The following is a description of a gene set: studied in species Mus musculus The directed movement of catecholamines, a group of physiologically important biogenic amines that possess a catechol (3,4-dihydroxyphenyl) nucleus and are derivatives of 3,4-dihydroxyphenylethylamine. Mouse Gene Set: GOBP_CATECHOLAMINE_TRANSPORT, and this is the list of marker genes: Hrh3, Slc18a1, Tor1a, Sdhd, Gck, Grm2 (glutamate receptor, metabotropic 2), Drd2, Kcna2, Syt1, Kcnb1, Dtnbp1, Rtn4, Adora2b, Chrnb2, Slc22a1, Tgm2, Ptgs1, Drd3, Cnr1, Ghsr, Pink1, Adora3, Oxtr, Crhr1, Oxt (NCBI Gene Id 18429), Slc29a3, Slc29a4, P2ry1, Mapk15, Npy2r (neuropeptide Y receptor Y2), Grk2, Htr1b, Entpd1, Cadps, Chrna4, Mecp2, Syt4 (NCBI Gene Id 20983), Rab3b, P2ry12, Htr6, Snca, Gdnf (NCBI Gene Id 14573), Syt7, Myo5a, Ptger3, Htr2a, Abat, Actb, Park7, Stx1a, Cxcl12, Gabbr1, Crhr2, Comt, Oprk1, Crh, Chrna7, Sncg, Chrna6, Slc6a2, Slc18a2, Slc22a3, Vip, Plcd1, Agt, Ly6e, Prkn, Drd1, Ffar3, Smpd3, Chga, Cartpt, Prkcb, Gnat1, Nat8l, Pcp4 (NCBI Gene Id 18546), Slc22a2, Syt11, Rab3a, Agtr2, Kpna4, Slc6a3, Chrm5, Xlr4a, Adora2a, Nisch, Xlr4b